The following is a description of a gene set: species: Mus musculus An endosomal sorting complex involved in membrane fission processes related to sorting of multivesicular bodies (MVB) in the endocytic pathway, cytokinesis and viral budding among other processes. Mouse Gene Set: GOCC_ESCRT_COMPLEX, and this is the list of marker genes: Vps25, Vps37b, Chmp7, Tsg101, Chmp4c, Mvb12a, Vps28, Mvb12b, Chmp2a, Chmp4b, Ubap1, Uevld, Vps37d, Ubap1l, Snf8, Vps37a, Chmp1a, Chmp1b2, Hgs, Chmp3, Chmp2b, Vps36, Stam, Vps37c, Diaph3, Chmp6, Chmp1b